The following is a description of a gene set: species: Homo sapiens Nonprogressive Applies to a disease manifestation that does not increase in scope or severity over the course of time, i.e., that does not worsen with age. Human Gene Set: HP_NONPROGRESSIVE, and this is the list of marker genes: ATN1 (NCBI Gene Id 1822), HOXB1, TRPV4, PDE10A, VLDLR, SAMD12, SCN8A, ATP2B3, FGF14, TUBB6, CHRNE (cholinergic receptor nicotinic epsilon subunit), MARCHF6 (membrane associated ring-CH-type finger 6), KRT12, STARD7, CLDN14, COL4A4, ILDR1, GFPT1, YEATS2, PMPCA, ATG5